Given this list of marker genes Dnajb2, Apoe, Gga1, Nedd4, Ddrgk1, Mapk9, Nupr1, Rnft2, Plk1, Rgma, Rnf185, Herpud1, Ndufa13, Apc, Egln2, Ezr, Dab2, Snx9, Trim32, Pttg1ip, Fbxw8, Snf8, Msn, Zer1, Dcaf1, Fbxo22, Cop1, Paqr3, Bcap31 (NCBI Gene Id 27061), Akt1, Vps35, Il33, Pacsin3, Dab2ip, Amer1, Trib3, Psmd10, Atg4b, Stub1, Tnfaip3 (NCBI Gene Id 21929), Ecscr, Csnk1e, Asb9 (NCBI Gene Id 69299), Lrp1, Snx33, Zfand2a, Sh3rf2, Mdm2, Sumo1, Eif2a, Rilp, Fzr1, Rad23a (NCBI Gene Id 93802), Rnf40, Abca2, Gabarap, Cblb, Sgsm3, Rack1, Aurka, Sirt2, Hspa1b, Atxn3, Nkd1, Sox9, Ifng, Sirt6, Asb5, Tnfsf12, Gba1, Gja1, Oaz1, Sorl1 (NCBI Gene Id 72910), Trib2, Osbpl7, Tiparp, Dda1, Sh3rf3, Tmem67, Rchy1, Xbp1, Trib1, Cbfa2t3, Vps28, Gpc3, Psen1, App, Sox17, Cdc20b, Ubqln1, Kcne2, Rnft1, Csnk1a1, Vcp, Csnk2a1, Usp13, Hsp90aa1, Axin2, Nrdc, Rbx1, Fbxw7, Cdkn1b, Ubr3, Zp3r, Socs5, Rab7, Nub1, Stx5a, Tnf, Prkn, Ndfip1, Gsk3b, Bag2, Cul4b, Rdx, Bag6, Nedd4l, E330034G19Rik, Mylip, Tmx1, Mapk8, Pabir1, Gpld1, Sec22b, Hamp, Cdc20, Tmem259, Dtl, Trim30a, Adam9, Det1, Nkd2, Oaz3, Gclc, Ern1, Trem2, Vps11, Fbxl5, Mapk15, Sirt1, Pias1, Ppp2r3a (protein phosphatase 2, regulatory subunit B'', alpha), Plk3, Sgta, Klhl40, Cav1, Itch, Rbx1-ps, Vgll4, Sh3d19, Ube2v2, Vip, Hspbp1, Gga3, Wnt5a, Fbxo11, Crebrf (NCBI Gene Id 77128), Psen2, Axin1, Ddb1, Wfs1, Adra2a, Snx1, Gsk3a, Pcsk9, Dact1 (dishevelled-binding antagonist of beta-catenin 1), Nop53, Tnfrsf1b, Atg7, Sumo2, Lrrk2, Rnf41, Nsf, Lpcat1, Dvl1, Zyg11b, Rhbdd1, Foxo1, Trf, Oaz2 (ornithine decarboxylase antizyme 2), Chfr, Eif2ak3, Ubqln2, Clu, Usp5, Hspa1a, Asb11, Plk2, Cd81, Il1b, C4bp, Ldlr, Socs4, Marchf2, Fmr1, Cul4a, Adam8, Ier3, Sh3rf1, Ubxn2a, Faf1, Prickle1 (prickle planar cell polarity protein 1), Rnf180, Bbs7, Tmtc3, Csnk1d, Rhbdd3, here is a description of the gene set: studied in species Mus musculus Any process that activates or increases the frequency, rate or extent of the chemical reactions and pathways resulting in the breakdown of a protein by the destruction of the native, active configuration, with or without the hydrolysis of peptide bonds. Mouse Gene Set: GOBP_POSITIVE_REGULATION_OF_PROTEIN_CATABOLIC_PROCESS